Given this list of marker genes MLLT3, TNFRSF18, PHTF2, GMPS, UBA5, BUB1B, TMX1, SSR1, VDAC1, GRHL1, RFC5, CDCA3, CENPM, MAP3K8, ZNF24, NCAPH, POLR2D, RCN2, NAMPT, ACTR6, SPCS3, C2CD5, RWDD3, MCM3, PDS5B, NEK2, STK32A, SAE1, ANKRD28, RAD54B, TINF2, AKAP11, MELK, ERI2, ST6GAL1, PTPN9, TEDC1, FAM210A, ALYREF, CCDC115, CSE1L, LIMA1, PRDM2, PPP1R3F, SNN, FUBP3, VIM, EIF2S3, PWP2, NCMAP, MCM4, NAA10, PFN2, NFKBIZ, HSD11B1, ARHGAP11A, DDX1, NDC80, VRK1, CUBN, GEN1, SNUPN, DCUN1D2, SHC3, VAMP3, FARSB, MYBL1, LRRC8D, DIP2A, TMED10, KPNA3, SMC3, PTPN1, UBE2A, MRPL40, PRMT3 (NCBI Gene Id 10196), DAP3, OSTC, CISH, ANLN, DHFR, KLHL2, TSEN15, ANKDD1B, PSMD13, CDK4, ADSS2, NUP107, TOX, SSX2IP, C7orf50, KIFBP, CDC27, MTFR2, NUP37, DIP2C, ACO2, IPO9, ERI1, HSPA14 (heat shock protein family A (Hsp70) member 14), COPS8, SLC29A1, SPAG5, PRPF38A, AURKA, STK24, RERE, IFT81, CD2AP, TMTC2, POLE3, PGAM5, TRAF6, RAB11FIP2, TRIM44, HPF1, POLR2B, ALG3, EXOC8, FES, CCND3, CBFA2T2 (CBFA2/RUNX1 partner transcriptional co-repressor 2), AGRP, LRP11, ACSL1, UTP18, FNBP1L, CENPC, TIMELESS, ABL1, TSG101, HAUS1, GALNT9 (polypeptide N-acetylgalactosaminyltransferase 9), DDX20, PSMA4, SOD1, QRSL1, CCSAP, USP27X, GPR83, IFTAP, NUP93, RB1, TIAM1, CTDSPL2, CEP57L1, KIAA1191, AHCYL2, PRKAR2B, PMF1, SRSF10 (NCBI Gene Id 89048), UBLCP1, VMA21, PDK3, CACTIN, VAMP7, C1orf198, CPD, HUS1, ECM1, TRMT11, COQ2, NXT2, EIF2S1, ANKRD13C, MCM7, KIF18A, WSB1, HNRNPM, BUB3, TIPIN, CDON, TRAT1, TACC3, AURKB, AVEN, UEVLD, MST1, TMEM267, ATP11C, TEAD1, NUDT5, PSMD12, MED19, DNAAF2, HAUS5, SHE, PPM1L, GINS2, CIP2A (NCBI Gene Id 57650), BMI1, DIDO1, DOCK1 (dedicator of cytokinesis 1), HAUS4 (NCBI Gene Id 54930), LTV1, SKA3, NUSAP1, CLTC, MIER3, here is a description of the gene set: from publication Hill JA, Feuerer M, Tash K, Haxhinasto S, Perez J, Melamed R, Mathis D, Benoist C (PMID 18024188) species: Homo sapiens Genes down-regulated in comparsion of ActCD8 versus ActTreg(see Fig. 1 in the paper for details). Human Gene Set: GSE7460_CD8_TCELL_VS_TREG_ACT_DN The transcription factor Foxp3 is usually considered the master regulator for the CD4+CD25+